The following is a description of a gene set: A G protein-coupled receptor activity occurring in the postsynaptic membrane that is part of a GPCR signaling pathway that positively regulates ion channel activity in the postsynaptic membrane. species: Homo sapiens Human Gene Set: GOMF_G_PROTEIN_COUPLED_RECEPTOR_ACTIVITY_INVOLVED_IN_REGULATION_OF_POSTSYNAPTIC_MEMBRANE_POTENTIAL, and this is the list of marker genes: GRM1, GABBR1, GRM5, GRID1, ADRB1, KCTD16 (potassium channel tetramerization domain containing 16)